The following is a description of a gene set: Mouse Gene Set: GOMF_PHOSPHATIDYLETHANOLAMINE_FLIPPASE_ACTIVITY Catalysis of the movement of phosphatidylethanolamine from the exoplasmic to the cytosolic leaflet of a membrane, using energy from the hydrolysis of ATP. studied in species Mus musculus, and this is the list of marker genes: Abcb1b, Atp11c, Atp8b5, Atp8a2, Atp11a, Abca4, Abcb1a